The following is a description of a gene set: Human Gene Set: GOMF_SNRNP_BINDING Binding to a small nuclear ribonucleoprotein particle. studied in species Homo sapiens, and this is the list of marker genes: STRAP, SNRNP70, RBM23, SNRPN (NCBI Gene Id 6638), LEMD3, SNRPD1, SNRPB, PRPF31, RBM39, SNRPA